The following is a description of a gene set: A cellular process that results in the biosynthesis of constituent macromolecules, assembly, and arrangement of constituent parts of a large ribosomal subunit; includes transport to the sites of protein synthesis. Mouse Gene Set: GOBP_RIBOSOMAL_LARGE_SUBUNIT_BIOGENESIS studied in species Mus musculus, and this is the list of marker genes: Rrs1, Sdad1, LTO1, Znhit6, Nle1, Ddx28, Mrm2, Rpl35a, Cinp, Ebna1bp2, Mak16, Noc2l, Ppan, Mdn1, Nip7, Fastkd2, Brix1, Trmt112, Heatr3, Rpf1, Wdr12, Nvl, Surf6, Nop2, Nop53, Eif6 (NCBI Gene Id 98777), Pak1ip1, Rcc1l, mt-Rnr2 (mitochondrially encoded 16S rRNA), Rpl35, Rbm34 (NCBI Gene Id 67649), Rpl10l, Urb1, Rpf2, Airim, Gtf3a, Malsu1, Rpl5, Zfp622, Afg2b, Ftsj3, Afg2a, Dhx30, Ddx18, Tma16, Rpl14, Bop1 (NCBI Gene Id 97992), Rpl11, Las1l, Nop16 (NCBI Gene Id 28126), Znhit3, Mrto4, Gtpbp4, Rpl7a, Nsa2 (NSA2 ribosome biogenesis homolog), Nol9, Rpl24, Rpl7, Wdr74, Rpl26, Rpl7l1, Pes1, Rsl24d1, Npm1, Rrp15